Given this list of marker genes MCM3AP, RBM15B, THOC1, WNK1, DDX25, DDX19B, FYTTD1, NCBP1, DDX39B, NUP88, NEAT1, MAGOHB, THOC2, NSUN2, DDX19A, THOC3, PCID2, MAGOH, RBM8A, HNRNPA2B1, NXF3, NUP107, YTHDC1, RAE1, NXT1, ENY2, TPR, CHTOP, ZC3H11B (NCBI Gene Id 648022), AGFG1, EIF4E, THOC5, SMG6 (SMG6 nonsense mediated mRNA decay factor), SETD2, NUP214, IWS1, XPO1, NCBP3, SMG7, ALYREF, ZC3H11A, NXF5, SARNP, CASC3, FMR1, HHEX, NXF2, EIF4A3 (eukaryotic translation initiation factor 4A3), NCBP2, THOC7, DDX39A, UPF1, NXF1, SRSF3, ZC3H11C, PABPN1 (NCBI Gene Id 8106), NXT2, SEM1, NUP85, NUP93, UPF2, NUP133, NUP155, ALKBH5, SMG1, NXF2B, SMG5, THOC6, POLDIP3, GLE1, AKAP8L, NUP160, C12orf50, here is a description of the gene set: The directed movement of mRNA from the nucleus to the cytoplasm. Human Gene Set: GOBP_MRNA_EXPORT_FROM_NUCLEUS species: Homo sapiens